The following is a description of a gene set: Human Gene Set: GOMF_ALDO_KETO_REDUCTASE_NADPH_ACTIVITY studied in species Homo sapiens Catalysis of the reaction: an alcohol + NADP+ = an aldehyde or a ketone + NADPH + H+., and this is the list of marker genes: RDH10, DHRS4L1, RDH13, CBR1 (NCBI Gene Id 873), RDH12, MIOX, KCNAB2, DHRS1, AKR1E2, AKR1C2, RDH8, DHRS3 (NCBI Gene Id 9249), DHRS4L2, AKR7A3, CBR3, ALDH3A1, AKR1A1, AKR1D1, AKR7A2, AKR1C1, AKR1B15, SPR, RDH14, RDH11, ADH4, DCXR, AKR1B1, DHRS2, KCNAB3, DHRS4, AKR1C4, KCNAB1, AKR1C3, DHRS7, AKR7L, AKR1B10